Given this list of marker genes Cxcl5, Rap1gap2, Ppm1h, Bmp5, 1110059G10Rik, Mcm6, Mpzl1, Vamp1, Map6, Kcnma1, Trhr, Zfp521, Slc12a6, Galnt11, Clec4a3, Gucy1a2, Asap1, Zwint, Fgl2, Ssbp2, Esr2, Tmem108, Ulk2, Nalcn, Scml2, Cttnbp2, Ctla4, Oprk1, St8sia4, Dlg2, Ice2, Clstn1, Nup133, Rcor3, AI182371, Tmpo, Arhgef7, Ano4, Bmp2k, Tshz3, Prim2, Dcaf7, Ino80d, Ccnb1ip1, Gabra2, Wtap, Rnf111, Atad1, Ptbp2, Fastkd3, Mpv17, Asb13, Crybg3, Rbm39, Mns1, Appl1, Pde1c, Zmym2, Rnf144a, Epb41l1, Stag2, Pum2, Trio (NCBI Gene Id 77730), Akap9, Wipf2, Golph3, Sla, Rif1, Synj1, Clpx, Spryd7, Zdhhc21, Wdfy3, Itga2, Kcnd3, Calca, Ppargc1a, Calm2, Sema3a, Smim26, Psmc6, Adnp, Pkn2, Ikzf3, Unk, Gmeb1, Sostdc1, Arid4a, Snx6, Dsc3, Emc7 (ER membrane protein complex subunit 7), Wsb1, Mthfd1, Slc6a19, Cd200l1, Rcn2, Zfp934, Rad21, Adamdec1, Sox2, Ccnc, Btaf1, Cd8a, Ddx50, Spry1, Pnpt1, Zfp148 (NCBI Gene Id 78647), Ccdc160, Rasef, Slc25a16 (solute carrier family 25 (mitochondrial carrier, Graves disease autoantigen), member 16), Pde10a, Fgf4, B3galt2, Peli1, Tada1, Elmo1, Mnat1, Homer1, Eif5b, Lrrc3, Ptprd, Rpf1, Trhde, Marchf7, Adpgk, Prpf4b, Rock2, Ptprr, 4921536K21Rik, Ptpn4, Gm5141, Carf, Ell2, Gucy1b1 (guanylate cyclase 1, soluble, beta 1), Mex3c, Kcne4, Vps26a, Cdk6, Smad4, Hhip, Zfx, Rnf138, Strbp, Rmdn3, Ubr5, Rab34, Tubgcp5, Anks1b, Sort1, Mtmr6, Itpr1, Plxna2, Cldn7 (claudin 7), Pdik1l (NCBI Gene Id 230809), Btg1, Dennd4a, Crebrf, Tardbp (TAR DNA binding protein), Camk1d, Vps13d, Zfp871, Fam227a, Psd3, Rc3h2, Zfp131, Itgb1, Matr3, Klhl20, Carmil1, Rnf38, Rps6ka3, Elavl2, Avl9 (NCBI Gene Id 78937), Klri2, Grsf1, Fam76b, Zfp281, Spag9, Med14, Spty2d1, Rab11fip2, Cks2, Clcn2, Zfp655, Npy6r, Sema7a, Dnajb4, Thrsp, Ndnf, Inpp4a, Mef2a, Cadm2, Naa20, Spag1, Bmx, Crx, Lin52, Kif3a, Wdr7, Arhgap6, Clk2, Snx16, Zfp182, Btbd35f23, Fgfr2, Zfp808, Cadm1, Lrch2, Tm9sf3, Hnmt, Tnrc6c, Hopx, Marchf6, Rai1, Hoxd1, Plcb1, Pigm, Phrf1, Lrrc42, Tob2, Tbc1d12, Pcnx4, Usp6nl, Camk2d, Sptbn1 (NCBI Gene Id 268394), Cops2, Hspbap1, Cnot4, E2f6 (E2F transcription factor 6), Mbnl3, Zfp507, Rundc3b, Polr1f, Hhex, Ncbp3, Fbxo33, Ccser1, Scamp2, Cyth3, Itch, Ppat, Rgs17, Vti1b, Gtf2b, Zbtb10 (zinc finger and BTB domain containing 10), Scn2a, Ssbp1, Rnf19a, Kdm5c, Rcbtb2, Vcan, Arap2 (ArfGAP with RhoGAP domain, ankyrin repeat and PH domain 2), Plppr4, Epc2, Nfkbia, Wrnip1, Slc8a1, Ankhd1, Zfp292, Ctdspl2, Stard13, Prdm12, Prkg2, Fut9, Pik3ca, Nr1d2, Gopc, Mylk4, Ppfia1, Il1rap (interleukin 1 receptor accessory protein), Diaph2, Adam22, Adamts1, Tbpl1, Ptprb, Pik3c2a, Cyp1b1, Prr12, Grm5, Pmp22 (NCBI Gene Id 18858), Esr1, Bmper, Fbxl17, Gdi2, Rab9b, Snap25, Alg6, Anapc2, Gabra1, Exosc3, Kif13a, Arhgap1, Lnpk, Gpatch8, Umod, Tbc1d22b, Pex14 (peroxisomal biogenesis factor 14), Map9, Rgmb, Zfp608, Sim1, Ptpre, Nufip2, Taok1, Zfp157, Osbpl8, Col5a2, Mbd2, Cntln, Ankrd1, Gabpb1, Cxadr, Cep350, Zbtb44, Ogfrl1, Ndn, here is a description of the gene set: species: Mus musculus Genes predicted to be targets of miRBase v22 microRNA mmu_miR_466n_3p in miRDB v6.0 with MirTarget v4 prediction scores > 80 (high confidence targets). Mouse Gene Set: MIR_466N_3P from publication Chen Y, Wang X (PMID 31504780)